The following is a description of a gene set: species: Homo sapiens Human Gene Set: MIR5197_5P Genes predicted to be targets of miRBase v22 microRNA hsa-miR-5197-5p in miRDB v6.0 with MirTarget v4 prediction scores > 80 (high confidence targets). from publication Chen Y, Wang X (PMID 31504780), and this is the list of marker genes: GTF3C4, FBN1, PLAG1, SLC44A1, VDAC1, UBR3, SPARC (NCBI Gene Id 6678), ABRAXAS2, BRWD3, SORBS1, SOX5, DCLRE1B, IL1A, NAPEPLD, MAGED2, FOXN2, DLG2, SEC31A, VIPR1, KMT2C, CTDSPL2, BACH2, MAGI2 (membrane associated guanylate kinase, WW and PDZ domain containing 2), EPHA4, MTARC1, JADE2, VCPIP1, MAP3K13, C19orf12, ATF6, ANKRD28, NFAT5, ATF2, LYVE1, SCUBE3, ITGB1, IREB2, DCAF6, NBEA, BICC1, CILP, DIP2B, TMEM161B, LIMS1, STRN, NAV1, PSAT1, A1CF, SRSF10, CSAD, CCDC15, VAMP3, GPAT4, NKX2-4, FAM120A, WDFY1, AP3M1, LRCH1, PCYOX1, MBNL1, ZNF711, RDX, CLCN3, GARRE1 (granule associated Rac and RHOG effector 1), CCDC169, TMEM168, DMD, TRAM1, SKIDA1, TXNL1, CACNA1E, CHMP2B, ZC3H4, ARHGEF37, MAPK4, ABHD12B (NCBI Gene Id 145447), PROX1 (prospero homeobox 1), USP10, NAV3, ZNF91, HS6ST2, ADGRG6, CHSY1, EPHA7, GJB2, CSTF1, SHOC2, PIGP, ZMYM2, KCNK10, BOLA2-SMG1P6, GPC6, GRID2, BVES, EMB, PHACTR2, ASXL3, TMEM182, NALF2, SAMD4A, PTPRG, BTBD3, MYC, ARPP19, ATP8A1, MATN3, CCDC190, SLC25A36, ZFAND4, PSME4, PDE8A, LBR (lamin B receptor), SLC24A2, PRKAA1, SLCO3A1, INTS6, SLITRK1, LUZP1, HOXA5, ODAD4, FRMD3, CTNNA2, CELSR1, USP3, KCNJ14, MGAT4A, TFDP2, CLDND1, GLS, STC1, ZBTB11, HOXA11, DAAM1, NDFIP1, PKP4, CILK1, ERP44, TAOK1, TAOK3, ZBTB25, FBXO8, CALN1, RNF208, PHKB, GABRB2, FNDC3A, DCX, ATL2, CNOT6L, CSNK1G1, SLX4IP, REPS2, BNIP3L, POU3F3, PABIR2, ZNF281, TSEN54, COL1A2, GUCY1A1, CAMTA2, ICA1, IFT81, SLC35A3, STEAP2, EXOC5, SAP18, PTPRZ1, ZBTB34, SKAP2, ADAM17, RPAP3, UNC45B, MAPK8IP1, CLOCK, G6PD, CMPK1, PPHLN1, PHLDB2, KCTD21, ANO6, GCC1, MSANTD2, KLF4, SFPQ, MAP3K4